The following is a description of a gene set: studied in species Homo sapiens The process whose specific outcome is the progression of the tongue over time, from its formation to the mature structure. The tongue is the movable, muscular organ on the floor of the mouth of most vertebrates, in many other mammals is the principal organ of taste, aids in the prehension of food, in swallowing, and in modifying the voice as in speech. Human Gene Set: GOBP_TONGUE_DEVELOPMENT, and this is the list of marker genes: NKX2-6, KIT, HDAC2, INTU (inturned planar cell polarity protein), HAND2, WDPCP, BNC2, NTF4, HDAC1, GLI3, HOXC13 (NCBI Gene Id 3229), CYP26B1, SIX1, TBX1, LEF1, SIX4, CTNNB1, WNT10B, WNT10A